Given this list of marker genes Rfc3, Terf2ip, Rpa3, Ten1, Acd, H3f4, H2ac6, Ccna1, Stn1, Rpa2, H4c14, H2bc12, Ctc1, Prim1, Rfc5, Ppp6c, Chtf8, H2ac4, H4c12 (H4 clustered histone 12), H2ac10, H2bc13, H2bc22, H2bc24, H2ac19, Daxx, H2bc9, Dkc1, H2bc11, H2ax, H2bc4, H2ac13, Prim2, H4c8, H2ab3, Nop10, H2bc21, Pif1, H2aj, H3f3b (H3.3 histone B), H2ac8, Pold3, Dscc1, H2bc15, Wrn, H2bc23, H2ac23, Dna2, Ppp6r3, H4c2, H2ab1, H2ac7, H2bc6, Atrx, H2bc3, H2bc26, Shq1, Pold2, Chtf18, H4c17, H4c16, Pola2, Pold4, Ccna2, Rtel1, H4c3, H4c9, H2bc7, H2ac12, H2ac11, H4c4, H2bc8, Cdk2, H2ac15, H4c6 (NCBI Gene Id 319157), Rfc1, H3f3a, H2ac22, Pold1, H2ab2, Wrap53, Pola1, H4c18, Rfc2, Terf2, Pcna, H2ac20 (NCBI Gene Id 319176), Ankrd28, Blm, Nhp2, H2bc14, Tert, Lig1, Fen1, H2bc1, H2ac18, Rpa1, H2ac24, Pot1a, Terf1, H2az2, H4c1 (NCBI Gene Id 326619), Rfc4, H4c11, Gar1, here is a description of the gene set: Mouse Gene Set: REACTOME_TELOMERE_MAINTENANCE studied in species Mus musculus Telomere Maintenance